Given this list of marker genes Cpt1c (NCBI Gene Id 78070), Cpt1b, Cpt2, Cpt1a, Lrat (lecithin-retinol acyltransferase (phosphatidylcholine-retinol-O-acyltransferase)), here is a description of the gene set: Catalysis of the transfer of a palmitoyl group to an oxygen atom on the acceptor molecule. species: Mus musculus Mouse Gene Set: GOMF_O_PALMITOYLTRANSFERASE_ACTIVITY